The following is a description of a gene set: The transport of organelles or other particles from one location in the cell to another along actin filaments. Mouse Gene Set: GOBP_ACTIN_FILAMENT_BASED_TRANSPORT species: Mus musculus, and this is the list of marker genes: Myo1c, Myo5a, Wasl, Actn4, Myo19, Myrip, Syne2, Fnbp1l, Sun2